Given this list of marker genes Prkar1b (NCBI Gene Id 19085), Camk1, Rps6ka6 (ribosomal protein S6 kinase polypeptide 6), Grin1, Grin2a, Grin2d, Calm1, Dlg4, Prkacb, Prkar2b, Nefl, Dlg3, Grin2c, Grin2b, Camkk1, Camk2b, Camkk2, Prkaca, here is a description of the gene set: electronically inferred by orthology from the curated human pathway part of: Neurotransmitter receptors and postsynaptic signal transmission This event has been computationally inferred from an event that has been demonstrated in another species.<p>The inference is based on the homology mapping from PANTHER. Briefly, reactions for which all involved PhysicalEntities (in input, output and catalyst) have a mapped orthologue/paralogue (for complexes at least 75% of components must have a mapping) are inferred to the other species. Reactome Pathway: Activation of NMDA receptors and postsynaptic events species: Mus musculus